The following is a description of a gene set: Diversity and size of the antigen-specific T cell receptor (TCR) repertoire are two critical determinants for successful control of chronic infection. Varicella zoster virus (VZV) that establishes latency during childhood can escape control mechanisms, in particular with increasing age. We examined the TCR diversity of VZV-reactive CD4 T cells in individuals older than 50 years by studying three identical twin pairs and three unrelated individuals before and after vaccination with live attenuated VZV. Although all individuals had a small number of dominant T cell clones, the breadth of the VZV-specific repertoire differed markedly. A genetic influence was seen for the sharing of individual TCR sequences from antigen-reactive cells but not for repertoire richness or the selection of dominant clones. VZV vaccination favored the expansion of infrequent VZV antigen-reactive TCRs, including those from naive T cells with lesser boosting of dominant T cell clones. Thus, vaccination does not reinforce the in vivo selection that occurred during chronic infection but leads to a diversification of the VZV-reactive T cell repertoire. However, a single-booster immunization seems insufficient to establish new clonal dominance. Our results suggest that repertoire analysis of antigen-specific TCRs can be an important readout to assess whether a vaccination was able to generate memory cells in clonal sizes that are necessary for immune protection. species: Homo sapiens Genes down-regulated in CD4-positive, alpha-beta memory T cell CD4-positive T cell vs naive CD4-positive T cell in seniors (52-75) after exposure to Zostavax, time point 7 to 9D. Comment: Table S3. BV and BJ gene segment usage in VZV-reactive CD4 T cells compared to naive and memory CD4 T cells (FDR <= 0.1). Human Gene Set: QI_CD4_POSITIVE_ALPHA_BETA_MEMORY_T_CELL_ZOSTAVAX_AGE_52_75YO_CD4_T_CELL_VS_NAIVE_CD4_T_CELL_7_TO_9DY_DN from publication Qi Q, Cavanagh MM, Le Saux S, NamKoong H, Kim C, Turgano E, Liu Y, Wang C, Mackey S, Swan GE, Dekker CL, Olshen RA, Boyd SD, Weyand CM, Tian L, Goronzy JJ (PMID 27030598), and this is the list of marker genes: TRBJ1-4, TRBV20-1, TRBV5-3, TRBV19 (T cell receptor beta variable 19), TRBV15, TRBV10-3, TRBJ2-1, TRBV14, TRBJ1-5